The following is a description of a gene set: studied in species Homo sapiens Up-regulated genes specific to esophageal adenocarcinoma (EAC) relative to normal tissue. To investigate the relationship between Barrett's esophagus (BE) and esophageal adenocarcinoma (EAC), we determined gene expression profiles of discrete pathological stages of esophageal neoplasia using a sequence-verified human cDNA microarray. Fifty one RNAs, comprising 24 normal esophagi (NE), 18 BEs, and nine EACs were hybridized to cDNA microarrays. Five statistical analyses were used for the data analysis. Genes showing significantly different expression levels among the three sample groups were identified. Genes were grouped into functional categories based on the Gene Ontology Consortium. Surprisingly, the expression pattern of BE was significantly more similar to EAC than to NE, notwithstanding the known histopathologic differences between BE and EAC. The pattern of NE was clearly distinct from that of EAC. Thirty-six genes were the most differentially modulated, according to these microarray data, in BE-associated neoplastic progression. Twelve genes were significantly differentially expressed in cancer-associated BE's plus EAC (as a single combined tissue group) vs noncancer-associated BE's. These genes represent potential biomarkers to diagnose EAC at its early stages. Our results demonstrate that molecular events at the transcriptional level in BE are remarkably similar to BE's-associated adenocarcinoma of the esophagus. This finding alarmingly implies that BE is biologically closer to cancer than to normal esophagus, and that the cancer risk of BE is perhaps higher than we had imagined. These findings suggest that changes modulated at the molecular biologic level supervene earlier than histologic changes, and that BE is an early intermediate stage in the process of EAC. Human Gene Set: WANG_ESOPHAGUS_CANCER_VS_NORMAL_UP from publication Wang S, Zhan M, Yin J, Abraham JM, Mori Y, Sato F, Xu Y, Olaru A, Berki AT, Li H, Schulmann K, Kan T, Hamilton JP, Paun B, Yu MM, Jin Z, Cheng Y, Ito T, Mantzur C, Greenwald BD, Meltzer SJ (PMID 16449976), and this is the list of marker genes: MCM7, SLC16A4, SOCS3, C1S, ACAA2, SSR2, LASP1, FKBP6, NR4A1, LAMA3, HSPE1, IFNGR1, MMP9, SDC4, SRI, IRF3, MST1L, PECAM1, JCHAIN, PF4, LAPTM5, LGALS2, CCR7, PIM2, UCP2, IGFBP3, GALNT3, CREB3, LUM, SPARC, PARP14, HSD17B3, IFITM1, ZNF593, NME2, IFI30, PIGT, TBXAS1, EIF1, COL9A2, IFT20, MMP7, HLA-DRB5, GPX2, LZTS3, C4A, ANXA5, SMTN, DAPK1, FOSB, MTMR11, RGS3, TRIM31, TAF15, KNG1, AMPD2, MEP1A, PMEPA1, C1R, SFXN3, COL5A2, FMOD, AGPAT2, CSF2RB, SERPINE1, GCC2, TNFRSF1B, COL3A1, SRGN, NOMO1, ELF5, GSTO1, BTN3A3, CTSH, FCER1G, FN1, BAK1, CALU, DUSP6, COL6A3, SERPING1, GNB5, TRIB2, ICAM2, ATF3, GPRC5B, ANXA4, SETD3, ECE1, P3H4, ARID5A (NCBI Gene Id 10865), PROM1, TNFRSF12A, ENC1, IGFBP7, DUSP2, TCF7L2, GBP3, ADGRE5, MECOM, KCNK1, TNFAIP3, HACD3, HLA-A, AQP9, THY1, ODC1, PNPLA2, KDELR2, CD34, MYADM, PLS1, CCL4 (NCBI Gene Id 6351), TSPAN18, DAP, JUN, MMP12, CDK2AP1, IFITM3, NOTCH4, ITGAM